Given this list of marker genes ELOVL6, HDGFL3, AP1S2, PKIA, MANBA, GP1BB, COA1, ATXN1, FANCI, MYH10, FAM20B, FGFR3, SQLE, SERPINH1, CYB5B (cytochrome b5 type B), AHCYL1, RRAS2, IFNGR1, ADAMTS3, TOM1L1, TNFRSF4 (NCBI Gene Id 7293), KEL, RFC4, MLLT11, CPM, CFP, HERC2P9, LCP1, SNTA1, DLEU1, CAPG, GATA2, TBPL1, PIR, CTSW, LAPTM4B, ITGAX, CFH, GOLGA8A, SORL1, TPM1, TYMP, CAST, IL2RG, PAFAH1B3, SCRN1, TNFAIP2, CTR9, GAD1, TRIB2, PLOD2, SC5D, BAMBI, IFI30 (IFI30 lysosomal thiol reductase), MORF4L2 (NCBI Gene Id 9643), PIM2, ALDH1A1, CD164, ORAI2, PRSS3, NTRK1, TRPC6, AKR1C1, GP9, TIMP2, LGALS1, MCM3, VCL, DEAF1, PCCB, CAV1, PDCD10, MYL4, GIT2, RAB27B, NAP1L3, PCNA, SERPINI1, ITGA6, SLC25A1, TFDP2, CSF2RB, MYO16, ULK2, AMD1, CD68, F2R, DHCR24, PROS1, RUNX1T1, ANXA2, NLRP3, S100A10, DLC1, LDB1, CLCN4, TJP2, CD58, ZMYND8, RYR3, LY86, STAC, DDB1, NCAM1, ACO1, TGIF1, MPPE1, AHNAK, VPS13A, PNN, TNFRSF1B (TNF receptor superfamily member 1B), UNC119, ITGA2B, RFC3, GABRE, HOXA9, TM7SF2, AOAH, ILF2 (interleukin enhancer binding factor 2), STAT4, GIPC1, TMSB15A, NET1, ANXA5, ICAM2, ELL2 (elongation factor for RNA polymerase II 2), CD200, KIF2A, CAPN2, HMGCS1, PLA2G6, ELOVL5, ARID5B, LDLRAD4, POU4F1, COL11A1, GOSR2, RHAG, NAE1, LARS2, ITGB3, NUP50, USP8, MED21, SFXN3, TRBC2 (T cell receptor beta constant 2), TRPC1, NR4A3, PTPN4, ANKLE2, PKIG, PSMG1, TGM2, GJA4, ZNF91, PAQR3, SLC7A1, ITSN2, DRAP1, MAST4, CXADR, TUSC3, ZBTB16, BAG2, FADS1, DOK5, CD180, PBX1, CASP1, MAN1A1, CRISP3, LAIR1, MRPL33, ALDH5A1, CDC42BPA, IL10RB, CSTA, AIF1, TIMP3, EVI2A, DDHD2, NR4A2, SERPINE2, CACNA2D2, TXNRD1, GP1BA, TPST2, GGH, TCIRG1, UBXN8, LAMA5, MAX, SAMHD1, here is a description of the gene set: Genes specifically expressed in FAB subtypes M2, M4, M5 and M7 of pediatric AML (acute myeloid leukemia). studied in species Homo sapiens Human Gene Set: YAGI_AML_FAB_MARKERS Most patients with acute myeloid leukemia (AML) enter complete remission (CR) after treatment with chemotherapy, but a large number of them experience relapse with resistant disease. To identify genes that are associated with their prognoses, we analyzed gene expression in 54 pediatric patients with AML using an oligonucleotide microarray that contained 12 566 probe sets. A supervised approach using the Student t test selected a prognostic set of genes, some of which are associated with the regulation of cell cycle and apoptosis. Most of these genes had not previously been reported to be associated with prognosis and were not correlated with morphologically classified French-American-British (FAB) subtypes or with karyotypes. These results indicate the existence of prognosis-associated genes that are independent of cell lineage and cytogenetic abnormalities, and they can provide therapeutic direction for individual risk-adapted therapy for pediatric AML patients. from publication Yagi T, Morimoto A, Eguchi M, Hibi S, Sako M, Ishii E, Mizutani S, Imashuku S, Ohki M, Ichikawa H (PMID 12738660)